Given this list of marker genes MTNR1B, WASF3, PARD3, CDK18, MYRF, NLGN2, CST7, TAC1, DICER1, EGR2, TENM4, TNR, ITGAX, GBA1, MAG, NMU, TPPP, S100B, NRDC, RIMS2, ABAT, UNC13B, IGF1, NCMAP, QKI, SOX10, TAC4, CARTPT, RIMS1, RNF10, NTSR1, TNFRSF1B, HCRT, ITGA2, ZNF488, DAG1, ATPSCKMT, CHRNB4, here is a description of the gene set: studied in species Homo sapiens Any process that activates or increases the frequency, rate or extent of a neurophysiological process. Human Gene Set: GOBP_POSITIVE_REGULATION_OF_NERVOUS_SYSTEM_PROCESS